Given this list of marker genes F830016B08Rik, Mrtfa, Pdlim1, Cnfn, Prss43, Arhgef6, Mri1, Opn3, Itgav, Nkx3-1, Agr2 (anterior gradient 2), Trim60, Ncam2, Clec7a, Nipal3, Lypd11, Slc38a10, Cd177, Ddr2, Iqsec2, Ibtk, Sema4g, Mphosph9, Nanos2, Lypd10, Fgfr1, Cipc, Slc4a8, Tdrkh (tudor and KH domain containing protein), Grik3, Arl8b, H2-T22, Klhl18, Rnf185, Agap1, Pld2, Zscan12, Syt14, Vps28, P4ha3, Ptprj, Cox10, Ddx46, Pianp, Gm128 (predicted gene 128), G6pc1, Slc26a1, Cdc40, Inhbb, Hpca, Zfp366, Adgra1, Scn3b (sodium channel, voltage-gated, type III, beta), U2af2, Lyrm4, Zmynd8, Zfand2a, Zfp148, Urad, Nrn1, Rxfp2, Bahd1, Chrna4, Dzip1, Vegfa, Tmcc1, Mef2d, Abat, Zyx, Pcmtd1, Nr6a1, Ncln, Hykk, here is a description of the gene set: from publication Chen Y, Wang X (PMID 31504780) Genes predicted to be targets of miRBase v22 microRNA mmu_miR_7078_5p in miRDB v6.0 with MirTarget v4 prediction scores > 80 (high confidence targets). species: Mus musculus Mouse Gene Set: MIR_7078_5P